The following is a description of a gene set: species: Mus musculus part of: Digestion This event has been computationally inferred from an event that has been demonstrated in another species.<p>The inference is based on the homology mapping from PANTHER. Briefly, reactions for which all involved PhysicalEntities (in input, output and catalyst) have a mapped orthologue/paralogue (for complexes at least 75% of components must have a mapping) are inferred to the other species. Reactome Pathway: Digestion of dietary lipid electronically inferred by orthology from the curated human pathway, and this is the list of marker genes: Pnlip, Pnliprp1, Lipf, Pnliprp2